The following is a description of a gene set: Mouse Gene Set: GOMF_SNRNP_BINDING studied in species Mus musculus Binding to a small nuclear ribonucleoprotein particle., and this is the list of marker genes: Snrpd2 (NCBI Gene Id 69107), Snrpa, Snrpb2, Snrpg (small nuclear ribonucleoprotein polypeptide G), Prpf31, Rbm39, Snrpe, Snrpd3, Strap, Snrpd1, Snrnp70, Snrpb, Snrpc, Snrpn